The following is a description of a gene set: Delivery of a fetus through surgical incisions made through the abdominal wall (laparotomy) and the uterine wall (hysterotomy). species: Homo sapiens Caesarean section Human Gene Set: HP_CAESAREAN_SECTION, and this is the list of marker genes: OPA1, ARSB, PTCD3, CACNA1D, COQ4, POR, ZFX, CYP11B2, SATB1, CYP11B1, CHD8, TAF1, AGTPBP1, POLR3A, TAOK1, ASXL3, MCM4 (NCBI Gene Id 780917), MTM1